The following is a description of a gene set: Human Gene Set: KEGG_MEDICUS_PATHOGEN_HIV_GP120_TO_CXCR4_GNAQ_PLCB_G_CALCINEURIN studied in species Homo sapiens HIV gp120 to CXCR4-GNAQ-PLCB/G-calcineurin. Pathway ID: N00432. Pathway type: Pathogen. Pathway class: nt06161 Human immunodeficiency virus 1 (HIV-1). Pathway Definition from KEGG: Env -> (CXCR4,CCR5) -> GNAQ -> PLCG -> IP3 -> Ca2+ -> CALM == CN -> NFAT, and this is the list of marker genes: PLCG2, PPP3CA, GNAQ, NFATC2, PPP3CB, NFATC4, NFATC1, CXCR4, NFATC3, CALM2, CALM3, PLCG1, PPP3CC, PPP3R2, PPP3R1, CALM1, CCR5